Given this list of marker genes PBX1, NET1, TMEM107, ARHGDIG, RGS6, CACNG7, SERPINH1, CHRNA10, CALB1, here is a description of the gene set: species: Homo sapiens Promyelocytic leukemia zinc-finger (PLZF) is a transcriptional repressor and tumor suppressor. PLZF is expressed in melanocytes but not in melanoma cells, and recovery of PLZF expression markedly suppresses melanoma cell growth. Several target genes regulated by PLZF have been identified, but the precise function of PLZF remains uncertain. Here, we searched for candidate target genes of PLZF by DNA microarray analysis. Pre-B-cell leukemia transcription factor 1 (Pbx1) was one of the prominently suppressed genes. Pbx1 was highly expressed in melanoma cells, and its expression was reduced by transduction with the PLZF gene. Moreover, the growth suppression mediated by PLZF was reversed by enforced expression of Pbx1. Knockdown of Pbx1 by specific small interfering RNAs suppressed melanoma cell growth. We also found that Pbx1 binds HoxB7. Reverse transcription-polymerase chain reaction analysis demonstrated that repression of Pbx1 by PLZF reduces the expression of HoxB7 target genes, including tumor-associated neoangiogenesis factors such as basic fibroblast growth factor, angiopoietin-2 and matrix metalloprotease 9. These findings suggest that deregulation of Pbx1 expression owing to loss of PLZF expression contributes to the progression and/or pathogenesis of melanoma. Genes down-regulated in A375 and 397 cells (melanoma) by forced expression of PLZF off adenovirus vector. from publication Shiraishi K, Yamasaki K, Nanba D, Inoue H, Hanakawa Y, Shirakata Y, Hashimoto K, Higashiyama S (PMID 16862184) Human Gene Set: SHIRAISHI_PLZF_TARGETS_DN